Given this list of marker genes PRDM1, HIF1A, EP300, IRS1, PTPRZ1, IL2RG, MDK, SIN3A, PIK3CA, HDAC3 (NCBI Gene Id 8841), ALKAL1, PIK3R1, ALK, PTPN6, STAT3, MYCN, PLCG1, PTN, DNMT1, SRC, SHC1, ALKAL2, PIK3R2, MYC, HDAC2, CD274, FRS2, PIK3CB, JAK3, HDAC1, here is a description of the gene set: Human Gene Set: REACTOME_SIGNALING_BY_ALK studied in species Homo sapiens Signaling by ALK